The following is a description of a gene set: The multiplication or reproduction of cells, resulting in the expansion of the population in the metanephros. species: Mus musculus Mouse Gene Set: GOBP_CELL_PROLIFERATION_INVOLVED_IN_METANEPHROS_DEVELOPMENT, and this is the list of marker genes: Egr1, Stat1, Osr1, Pdgfb, Shh, Bmp7, Myc, Gpc3, Wt1, Ptch1 (NCBI Gene Id 77214), Pdgfrb